Given this list of marker genes THBS1, TK1, CCND2, CDCA7, TP53, LDHA, PTMA (NCBI Gene Id 91418), EIF2A, CCNB1, NPM1, BAX, YBX1, CUL1, DNPH1, ID2, CDC25A, CDK4, POLR3D, DDX18, EIF4E, BCAT1, CAD, here is a description of the gene set: Genes up-regulated in MEF cells (embryonic fibroblasts) after knockout of PML and whose promoters were bound by MYC. c-myc is a well-known proto-oncogene encoding for a transcription factor that needs to be tightly regulated in order to preserve cell homeostasis. The Promyelocytic Leukaemia gene product PML plays an important role in cell growth and survival, and resides in discrete subnuclear structures called Nuclear Bodies (NB). We performed comparative analysis of the expression of 40 Myc target genes and of Myc binding to their regulatory regions both in wild-type and PML knockout cells. We demonstrate that if PML is absent, despite Myc binding to the DNA regulatory sequences is unchanged, the expression profile of several Myc target genes is altered. PML is largely involved in gene regulation, via recruitment of several transcription factors and cofactors to the NB. Consistently, we show that Myc partially localizes to the NB and physically interacts with PML, and that this localization depends on Myc expression levels. As deregulation occurs to both activated and repressed Myc target genes, we propose that PML influences Myc transcriptional activity through a mechanism that involves the control of Myc post-translational modifications. studied in species Mus musculus Human Gene Set: CAIRO_PML_TARGETS_BOUND_BY_MYC_UP from publication Cairo S, De Falco F, Pizzo M, Salomoni P, Pandolfi PP, Meroni G (PMID 15735755)